Given this list of marker genes Picalm, Nrg1, Ngf, Epo, Rasgrp1, Rasgrf1, Ntrk1, Sos1, Shoc2, Kitl, Mmd2, Hras, Notch1, Src, Erbb2, Stk19, Notch2, Csf1, Igf1, Dgki, Fgf10, Rasgef1a, Itpkb, Map2k1, here is a description of the gene set: Any process that activates or increases the frequency, rate or extent of Ras protein signal transduction. studied in species Mus musculus Mouse Gene Set: GOBP_POSITIVE_REGULATION_OF_RAS_PROTEIN_SIGNAL_TRANSDUCTION